The following is a description of a gene set: Histone acetyltransferases (HATs) and deacetylases (HDACs) function antagonistically to control histone acetylation. As acetylation is a histone mark for active transcription, HATs have been associated with active and HDACs with inactive genes. We describe here genome-wide mapping of HATs and HDACs binding on chromatin and ﬁnd that both are found at active genes with acetylated histones. Our data provide evidence that HATs and HDACs are both targeted to transcribed regions of active genes by phosphorylated RNA Pol II. Furthermore, the majority of HDACs in the human genome function to reset chromatin by removing acetylation at active genes. Inactive genes that are primed by MLL-mediated histone H3K4 methylation are subject to a dynamic cycle of acetylation and deacetylation by transient HAT/HDAC binding, preventing Pol II from binding to these genes but poising them for future activation. Silent genes without any H3K4 methylation signal show no evidence of being bound by HDACs. Human Gene Set: GSE15735_CTRL_VS_HDAC_INHIBITOR_TREATED_CD4_TCELL_12H_UP species: Homo sapiens from publication Wang Z, Zang C, Cui K, Schones DE, Barski A, Peng W, Zhao K (PMID 19698979) Genes up-regulated in CD4 T cells: control versus treated with HDAC inhibitors for 12h., and this is the list of marker genes: DMAC1 (distal membrane arm assembly component 1), CDPF1, SOD2, PCSK1, TXNDC5, TMEM17, ALDOA, FICD, TTI2, RPL37A, SNX33, RASL10A, GAR1, GCLC, MDN1, TUSC2, CNP, SH3GLB2, NME3, ALDH7A1, C14orf119, ZNF790 (NCBI Gene Id 388536), MRGPRE, CYP2U1 (NCBI Gene Id 113612), GORASP1, ADD1 (NCBI Gene Id 118), COASY, PPCS, ACBD4, TFAM, YPEL3, SH3YL1, USHBP1, CNR2, PABPC4, SH3KBP1, MTARC2, KRT20, RPP25L, SUSD1, SPESP1, JAK1, GOT1, TK2, EFCAB2, LSM7, WASHC5, UPK3A, RTL6, SEC22C, ALDH2, SPIB, TACSTD2, ANO10, MRPS35, MYBBP1A, ELP3, SERINC3, SCML4, FARSA, MRM1, RPS26, RGS20, GSTM5, UBXN6, LNX2, TXNRD3, PJA1, KCNK5, EZR, REPIN1, SLC16A1, DENND5B, CLUH, MAP4K1, TRAP1, ATP2A3, MAN1A2 (NCBI Gene Id 10905), CAMK2D, GPN2, SIT1, PRKAG1, PIAS4, SLC2A1, MCCC1, SGMS1, ATIC, CD99L2, KLHL24, MCF2L, SELENOW, GCOM1 (NCBI Gene Id 145781), C9orf85, QTRT1, NARS2, POLR3H, CNRIP1, UBE2H, ATP5F1D, SYS1, PCED1B, ZFAND2B, UGCG, ESYT1, SIDT1, TBC1D14, STARD10, CIB1, SPNS2, PDCD2 (programmed cell death 2), C19orf38, RPL13A, CPNE5, SLC25A53, DPH7, MATN4, TMEM223, FTX, ARPC5L, TRAF4, IRF2BPL, GUCD1, SVBP, KIAA1549, ENTPD5 (NCBI Gene Id 957), KLHL21, PQBP1, TUT4, CAPN5, TREML2, CCM2, PDF, ADPRM, RBM4, POU6F1, ARHGAP26, PPM1E, CD40, TCOF1, MTNAP1, TRIM35, KTN1, TAPT1, KCNG1, BCDIN3D, PHYKPL, GSTT2, IRX1, CTPS2, PPP1R13B, HOPX, UBIAD1, PPME1, ZSCAN20, OSGEPL1, ACSS2, GEMIN7, B3GALNT2 (beta-1,3-N-acetylgalactosaminyltransferase 2), MIEN1, B3GNT8, C1GALT1, PRMT2, CNOT10, WDR74, CCDC71L, AVP, CBR1, LHFPL2, MARVELD2, DCBLD1, CKAP4, SNX25, ABHD14B, PPIL1, ICAM2 (intercellular adhesion molecule 2), COG6, BDH1, TRAK2, GPAM, SLC16A6, SLC4A11, IQCB1, FBXO9, CTSE, RIOX1, PPP2R1A, ZNF239, BIN1, SZRD1, DDX54, RPL36A (NCBI Gene Id 6173), BACH2, TRABD, FYTTD1, PTGR3, IRAK3, TMEM216, NOXRED1, RECQL5, DHX32